The following is a description of a gene set: studied in species Homo sapiens Any process that stops, prevents or reduces the frequency, rate or extent of a small molecule metabolic process. Human Gene Set: GOBP_NEGATIVE_REGULATION_OF_SMALL_MOLECULE_METABOLIC_PROCESS, and this is the list of marker genes: PRMT3, MTCH2, SIRT6, SNAI1, UGT1A8, INSIG2, ETFBKMT, PGK1, ANGPTL4, SNAI2, FMO1, PID1, SOX9, FBP1, NUPR1, GSK3A, MIR27A, UGT1A3, SLC22A13, CEACAM1, INS, MIR766, GFI1, NFKB1, ATP2B4, FLCN, MALRD1, UGT1A1, DKKL1, ADIPOQ, SCAP, TIGAR, PRKACA, ACADVL, GCHFR, TRIB3, ERFE, MIR548P, ERLIN2, ALDOB, WNT4, SERPINA12 (serpin family A member 12), FMO2, WDTC1, CLK2, DDIT4, ERLIN1, C1QTNF12, AKR1C3, BMP2, GIT1, SIRT4, CDA, FGF19, MIR98, MIR33A, MIR185, ACACB, APOC1, MST1, MIR27B, PPP2CA, UGT1A6, BMP5, TP53, GGCX, TRIM63, CBFA2T3, MIR204, SLC4A1, PFKFB1, PLIN5, SIRT1, UGT1A10, DGAT2, C7orf50, USP7, MIR132, MTCL2, APOE (NCBI Gene Id 99), PIBF1, MIR21 (microRNA 21), EP300, REST, AKT1, APPL2, PRKG1, DCAF5, CYP7A1, CH25H, MIR30C1, TCF7L2, INSIG1, STAT3, IER3, PARP1, CRY1, GMPPA, APOC3, NCOR1, ACMSD, PPARA, ACADL, AMDHD2, C1QTNF3, FMO4, FIS1, UGT1A7 (NCBI Gene Id 54577), NR0B1, PLEK, ATP5IF1, PROX1, ACTN3, UGT1A9, ATCAY, MFSD2A, RD3 (NCBI Gene Id 343035), GCK, LEPR (NCBI Gene Id 3953), MIR675, SIK1, KAT2A, MIR342, UBR4, UGT1A4, PGP, HDAC4, DKK3, KLHL25, TSPO, BRCA1